The following is a description of a gene set: part of: PLC beta mediated events Reactome Pathway: Ca-dependent events species: Mus musculus electronically inferred by orthology from the curated human pathway This event has been computationally inferred from an event that has been demonstrated in another species.<p>The inference is based on the homology mapping from PANTHER. Briefly, reactions for which all involved PhysicalEntities (in input, output and catalyst) have a mapped orthologue/paralogue (for complexes at least 75% of components must have a mapping) are inferred to the other species., and this is the list of marker genes: Pde1c, Calm1, Adcy7, Camkk2, Adcy8, Prkacb (NCBI Gene Id 18749), Prkaca, Camkk1, Prkcg, Prkar2b, Prkca, Pde1b, Prkar1b, Adcy5